The following is a description of a gene set: part of: Cytosolic sensors of pathogen-associated DNA  species: Mus musculus electronically inferred by orthology from the curated human pathway This event has been computationally inferred from an event that has been demonstrated in another species.<p>The inference is based on the homology mapping from PANTHER. Briefly, reactions for which all involved PhysicalEntities (in input, output and catalyst) have a mapped orthologue/paralogue (for complexes at least 75% of components must have a mapping) are inferred to the other species. Reactome Pathway: DEx/H-box helicases activate type I IFN and inflammatory cytokines production, and this is the list of marker genes: Nfkb1, Myd88, Rela, Nfkb2, Irf7